Given this list of marker genes BHLHE40, TLR8, ABCG1, ELF4, TIMP2, SMARCD3, ALOX5, KIT, H2AC8, AQP9, GNA15, HSPA6, CYP27A1, CXCR1, SPHK1, WNT5A, DHCR7, VEGFA, CEBPB, FCGR2A, SMURF2, CTSL, INSIG1, APOB, BLVRA, CHKA, CYP1B1, IFNGR1, KDM5B, SLC23A2, TGFB1, CDKN1A, PPBP, CD1D, HCK, THBD, SPARC, HBEGF, ABCA1, BCAT1, MPP1, CCR1, LRRC17, CLN8, PMP22, ACSL1, ZNF134, CXCL8, C3AR1, PFKFB3, ENG, GLUL, EPHA4 (EPH receptor A4), ABCB1, UPB1 (NCBI Gene Id 51733), CHI3L1, RAB33A, DPH1, SLC7A5, IGFBP3, P2RY2 (NCBI Gene Id 5029), PERP, PPARD, CD14, DSE, EGR1, CIAO1, MYLK, IER3, CKB, FBP1, RAB13, IFNGR2, CD93, NRG1, CLU, SLC16A6, CHN1, PDLIM7, CD58, BIRC5, B4GALT5, FPR1, DHRS3, CSF2RA, SLC22A4, TNFRSF1B, RRAGD, COL7A1, BST1, NCF2, QSOX1, TIE1, P2RX1, TGFBI, DAPK2, ADM, MECP2, TLR2, CDA, HPSE, HMOX1, MARCKSL1, TMBIM1, PROS1, MAFF, ADAP2, CREM, MAPK7, SMAD7, HS3ST1, SHC1 (SHC adaptor protein 1), CTSB (NCBI Gene Id 3896), EPAS1, SLC2A3, ZNF395, MAFG, IRAK3, TNFRSF1A, YARS1, GM2A, GAB2, ADGRE2, NOD2 (NCBI Gene Id 8135), RGS16 (regulator of G protein signaling 16), HNMT, DUSP4, SYNGR3, SCML1, SERPINB13, RARA, RGS1, MARCO, ULK1, RGS3, SGSH, IL21R, C5AR1, SC5D, SLA, PLIN2, ANPEP, PTGES, MCAM, RNASE2, PRSS23, SERPINB2, THBS1, KCNJ15, CCL20, ARHGAP8, TNS1, NBL1, PLAU, DKK3, PLAAT1, SLCO4A1 (solute carrier organic anion transporter family member 4A1), CYP1A1, CD9, here is a description of the gene set: from publication Smirnov DA, Foulk BW, Doyle GV, Connelly MC, Terstappen LW, O'Hara SM (PMID 16540638) Human Gene Set: SMIRNOV_CIRCULATING_ENDOTHELIOCYTES_IN_CANCER_UP studied in species Homo sapiens Genes up-regulated in circulating endothelial cells (CEC) from cancer patients compared to those from healthy donors. Increased numbers of endothelial cells are observed in peripheral blood of cancer patients. These circulating endothelial cells (CECs) may contribute to the formation of blood vessels in the tumor or reflect vascular damage caused by treatment or tumor growth. Characterization of these cells may aid in the understanding of the angiogenic process and may provide biomarkers for treatment efficacy of angiogenesis inhibitors. To identify markers typical for CECs in cancer patients, we assessed global gene expression profiles of CD146 immunomagnetically enriched CECs from healthy donors and patients with metastatic breast, colorectal, prostate, lung, and renal cancer. From the generated gene profiles, a list of 61 marker genes for CEC detection was generated, and their expression was measured by real-time quantitative PCR in blood samples from 81 metastatic cancer patients and 55 healthy donors that were immunomagnetically enriched for CECs. A set of genes, among which novel CEC-associated genes, such as THBD, BST1, TIE1, POSTN1, SELE, SORT1, and DTR, were identified that were expressed at higher levels in cancer patients compared with healthy donors. Expression of the VWF, DTR, CDH5, TIE, and IGFBP7 genes were found to discriminate between cancer patients and healthy donors with a receiver operating characteristic curve accuracy of 0.93. Assessment of the expression of these genes may provide biomarkers to evaluate treatment efficacy.